The following is a description of a gene set: The conversion of a differentiated cell of one fate into a differentiated cell of another fate without first undergoing cell division or reversion to a more primitive or stem cell-like fate. species: Mus musculus Mouse Gene Set: GOBP_TRANSDIFFERENTIATION, and this is the list of marker genes: Pdx1, Smad3, Tbx5, Gata4, Asnsd1, Cd34, Lif, Neurog3, Tert, Mef2c, Got1, Insm1